The following is a description of a gene set: studied in species Homo sapiens Human Gene Set: GLI3_TARGET_GENES Genes containing one or more binding sites for (GLI3) in their promoter regions (TSS -1000,+100 bp) as identified by GTRD version 20.06 ChIP-seq harmonization. from publication Yevshin I, Sharipov R, Kolmykov S, Kondrakhin Y, Kolpakov F (PMID 30445619), and this is the list of marker genes: SNHG29, HNRNPL, PTPRA, UQCRC1, NADK2, DNAJC18, MAP4K1, NUCB2, TICAM1, ALDH18A1, CEPT1, HDHD5, MADCAM1-AS1, SNORD13, CCDC12, SLC26A6, AIFM1, CENPK, CCDC7 (NCBI Gene Id 79741), MEPCE, MRPS27 (mitochondrial ribosomal protein S27), ARHGAP27, PLAC8, TMEM161B-DT, MKLN1-AS, COPS4, RPS3, DPCD, ATP10B, SLC24A1, RXRB, CHEK1, DNM1L, FAM83B, SNORA3A, KHDRBS1, NFYC, ENSG00000200288, RN7SL346P, PIP4K2B, ARL6IP1, SETD4, RPS6KB1, DENND5B-AS1, NFE2L2, TAF12-DT, HNF4A, LINC01023, CXCL1, PRH1, LINC02960, KPTN, HIBCH, IFT80, NUF2, SMTN, POLR1F, SNRPD1, EEF1A1 (eukaryotic translation elongation factor 1 alpha 1), ZFAND1, AIMP1, RPS8, ZNF789, RPS5, DUS2, H2BC9, VMAC, SNORD54, RNU6-7 (NCBI Gene Id 101954275), STC2, GSK3B, YARS2, ACTN1, STARD3, TARS1, SPATS2L, RNF7, TAF12, TARS1-DT, CSE1L-DT (NCBI Gene Id 102723483), PLAG1, ITPRID2-DT, ZSCAN30, SEMA3C, FIS1, DHCR24, HYKK, RNY3, GDPGP1, RBM18, SNORD65, WDR6, WDR89, LMLN, SNORD15A, CHKB, REEP4, ZBED4, PCBP1-AS1, ATP9B, TMEM138, GTF2H1, THUMPD3, ITPRID2, GGA3, SIDT1, RBM33-DT (RBM33 divergent transcript), ANKS1A, DLG1, WBP1, CEP63, FMC1, CFDP1, TXNDC5, SETD9, PSMD5, POU2F1, HPS5, ATG12, MDP1, FAM227B, USP3, MIR3678, RBM33, UHMK1, LINC01719, RNU2-2P, COX5A, C11orf71, SNRPA, SMC4, MCEE, ZFAND6, RTF1, CCDC28B, TIPARP-AS1, TIMMDC1-DT, CKAP2-DT, TPRN (NCBI Gene Id 286262), ZNF12, MUTYH, CEP164, ANAPC13, C1orf131, SRSF10, RHOF, OBI1, RAD17, GLYCTK-AS1, R3HDM2, SYPL1, EXOSC3, GGCX, LINC02541 (long intergenic non-protein coding RNA 2541), GCC1, COPS2, F12, PSPC1, WDR74, AATF, ITGB1-DT, MKLN1, TIMM13, RPL27A, ANKMY2, TBCK, MIR4521, GDPD1, HYAL3, MED29, MRPS7, SNHG16, SLC38A6, BZW2, SRP14, TRMT10C, ILVBL, CCHCR1, IL5, UFC1, TMEM68, PPP1R3E, NUP98, CLRN3, USP1, TMX1, SPRYD4, PRPF40A, GRK6 (G protein-coupled receptor kinase 6), SZRD1, TMEM51-AS1, VRK2, MLKL, ENSG00000227218, RPL13A, IQCG, TRIM27 (NCBI Gene Id 5987), SLC39A7, PHC3, WDR5B, ACOT8, TMEM14B-DT, NOCT, GSK3B-DT, HECTD4, NUBPL-DT, TGS1, TRA2A, LTO1, ZRANB3, CKAP2L, DTX4 (NCBI Gene Id 23220), HERC3 (HECT and RLD domain containing E3 ubiquitin protein ligase 3), ZNHIT1, GOLGA3, BYSL, IRF2BP2, NME7, PTGES3, RBM48, ABALON, IPO4, INTS14, SEC14L2, N6AMT1, TUFT1, AARSD1, ADGRV1, AP1B1, HCFC1R1, TBC1D30, RNU5F-1, SNX3, HMCES, PPAT, BLZF1, ACAD9, NDUFA11, ZNRF2, PCK2, STAT2, PROCA1, ENSG00000255647, SLC39A11, PSMD9, ALDH2, SRSF5, PSME2P3, NMI (N-myc and STAT interactor, NCBI Gene Id 9111), LRRC1, GAU1, ITPKA, GMEB1, NFX1, RNF32, EDEM3, COMMD10, R3HDML-AS1, STYXL1, CHD1, SLC38A1, ST13 (NCBI Gene Id 8937), EFCAB15P, CPSF4, WDR1, PSMD6, EPB41L5, TMEM123-DT, KLHL18, USO1, PRR4, MUC1, MYL12A, OSBPL8, CCDC91, EEF1B2, CEP57L1, TEC, SECISBP2, WDR75, METTL17 (methyltransferase like 17), LCA5, RNU12, TIPARP, DAXX, THOP1, SLC9A3R1-AS1, KLHL20, DDX31, MCM8-AS1, ESYT2, ZFYVE16, MYD88, IPMK, TCAF1, SIK3 (SIK family kinase 3), THAP2, MON1B (NCBI Gene Id 22879), PPP1R12A, SLC9A3-AS1, FANCC, TMEM161B, FAM98C, KANSL1-AS1, NMNAT1, PHF7, MBD4, RALB, LINC02038, CISD1, CCDC61, STIM2-AS1, TMEM123, WDSUB1, IKBIP, HMGB2, PPM1B, FZD1, METTL5, RAB4B, DLG4, ZNF282, DPM2, GAS5, TMEM87A, IL20RA, RBM27, RPS19, CRLS1, H2BC26, ERCC6L2-AS1, PFAS, UBXN8, RCHY1, MAN2A2, GLYCTK, POMT1, IFT52, LARS1, TYW5, AKAP11, EFHD1, SH2B2, ZSCAN29, STK11IP, YJU2B, SNORD55, SPINT1, PER1, SUCLA2-AS1, SMKR1, PTPN23, PTCD1, RIMOC1, LCA5L, RN7SL1, PSMD12, XPNPEP3, RAG1, LINC01089, MRPS33, HMGB3P22, CCDC18-AS1, DDX55, ZNF354B, NAA40, ANXA2, WDR27, RNU6-2, UBAP1, PLEKHA8, PAICS, TMEM14B, MINDY2, MIR4754, SMARCAD1, NAP1L1, CERNA3, ABHD16A, EBAG9, PANK3, HSP90AA1, KCTD7, SLC2A13, TAF1C, UQCRC2, APAF1, PANK2-AS1, TTC41P, GOLGA5, EIF3K, TP53BP1, ANKRA2, DFFB, PSMC2, GOLGA1, RPA2, KCTD2, NUP214, RBM4, NCOR2, MFN1, HDAC6 (NCBI Gene Id 100820762), MFN2, ZMYND8, ZNHIT3, RPS20, MRNIP, ICE2, JAG1, LARP1, RAB4B-EGLN2, ZNF35, SEPTIN7-DT, ERCC1, TLL2, PRC1, SMU1, RPS9, PDE4D, HOXB6, VAMP8, H2AC25, CCDC34, CAP1, ZFP36, EIF2AK4, POLR2I, ENSG00000275740, UTP15, RAB11A, MAP3K5, CCDC125, ITGB1 (NCBI Gene Id 3688), TMEM62, PCNX4, IPP, SNORD49B, NABP2, FDXR, LDHB, RNF32-DT, NAPA-AS1, HELQ, TTI2, ACTG1P25, SELENOK, SOAT1, GLCCI1, NCOA3, SMIM27, PIK3C2A, CLPB, ZBTB18, SKA1, MGST3, RPL37, SAR1B, H3C6, ACOX3, DNAJC2, TNS2-AS1, APRT, SEPTIN7, EFCAB14, SHROOM1, DCP2 (decapping mRNA 2), GZF1, SLC43A2, TMEM141, ARL6IP6, HNRNPH1, EDC3, RUFY2, GCHFR, KAZALD1, UBXN2A, TRA2B, TMX2, HMGCR, H3-3B, CNNM2, WDR45, PRDM1, GPN2, ANKLE2, STIM2, FLJ30679, NFU1, ADRM1 (ADRM1 26S proteasome ubiquitin receptor), RPS29, TMBIM4, RAD1, RALY, DHCR24-DT, CHCHD7, DUSP28, MRRF, TAF9, TOE1, RAPGEF6, DCAKD, SIPA1L3, FASTK, TEFM, NUBPL, PLEKHG1, ZNF384, RGS5, CETN3 (centrin 3), DDX23, COG5, THUMPD1, SNORD72 (small nucleolar RNA, C/D box 72), MED19, ITGB5, DTWD1, TOPORS, TMEM91, CTTN-DT (CTTN divergent transcript), NEDD9, G3BP1, LINC01465, ALDH1A3-AS1, CTC1, SMC3, BAP1, ZNF460, PPP2R5B, BTN2A2, MRE11, NAA80, CCNI2, ZNF688, EFCAB5, SLC25A45, SMG1, AP1M1, ZBTB45, SNORD1C, TRIM8-DT, IFT122, EIF2D, NEURL4, PTPN11, ENY2, CIMAP1B, NMT1, NUDCD3, SNORD46 (small nucleolar RNA, C/D box 46), MIR6508, SGO1-AS1, FBXL18, SNORA13, NCOR1, RPS6KA5, ENSG00000232995, PNPLA3, PRR12, MAP1A, PKP2, TMEM259, ARHGEF39, KIF9, C1GALT1, SEC24A, AFF4-DT, FKBP14, HDLBP, POLL, NR2F1-AS1, ZFC3H1, NFKBIZ (NCBI Gene Id 64332), PCBP1, CRYZ, HDHD5-AS1, RPL30P11, TAF1B, ACLY, REX1BD, TAF11, RAD52, MED13L, PPIA, WDR20, SVIP, ZNF271P (NCBI Gene Id 58502), ANKRD10, MATCAP1, ACTMAP, G3BP2, DYNC2I1, MFSD4B-DT, CTSH, HARS1, PRKCI, SRP14-DT, NOD1, ILF2, THOC6, RSRC2, BSCL2, FNTB, GMNN, ADPRHL1, RHEBL1, TUBA4A, ADAP2, GALK2, THRB-AS1, FBXL5, OSR2, IL23A, ZNF133, UGP2, RNF138, CKAP2, AKAP9, HAUS2, SEMA4F, SESN1, TASP1, SLAIN2, ZMPSTE24, LRP6, TBCB, TMEM242-DT, ADGRG6, MNX1, USF1, IARS1, GNPAT, SMARCAD1-DT, RRM2B, SART3, PAN2, C1orf210, PANK2, OSTC, MINDY2-DT, GTF3C4, SLC50A1, TAS2R14, SGO1, PPM1J, ENTPD1-AS1, GALNT11, POP7, TCF19 (transcription factor 19), FOXP4, CYB561A3, MAP3K14-AS1, RNU5D-1, SEPTIN2, WDR55, TUFM, PATJ, SH2B1, MIEF1, TUBD1, PCNX4-DT, PLOD3, MTHFSD, POP5, DAPK3, TNPO2, LUC7L2, APBB2, CTTN, VPS13B-DT, PAXIP1-AS2, NKTR, LZIC, EHD1, ACADVL, TRIM8, PPFIBP1, FMC1-LUC7L2, DGLUCY, SMG1-DT, TRMO, PABIR1, MRNIP-DT, CIC, RAD50, SPINT1-AS1, RLF, C2CD4A, LINC01635, NDUFAF4P1, SNORD49A, GANC, MAIP1, COL6A4P1, DSN1, LIN54, LINC00339, TBX6, GRB2, TMEM51, PSAT1, ENC1 (ectodermal-neural cortex 1), PSMA4 (proteasome 20S subunit alpha 4), AURKB, NXT1, ARGLU1, UBXN4, FUT11, GLRX, RSBN1, PPWD1, EPB41L4A-AS1 (NCBI Gene Id 114915), DOCK4, SET, TRMT44, CFL1P1, CIPC, ATIC, LRRC57, MAP4, AK6, POLDIP3, HNRNPLL, SLC17A7, R3HDM2-DT, CEP104, PHF5A, SAMD1, CHKB-CPT1B, NOSIP, TMEM41A, GABARAP, KCTD5 (potassium channel tetramerization domain containing 5), ENTPD7, TMEM50B, IER3, MARCHF3, MAGOHB, HIKESHI, DRAM2, MIRLET7I, ENSG00000275765, MED18, KLHDC2, PGAP2, EIF2B2, VPS13B, POU2F1-DT, SNORA73B, RBM7, TIMMDC1, MED20, ISCU, TSSC4, UBB, ERCC6L2